Given this list of marker genes H1-3, HMGB2, H1-0, H1-2, KPNA1, H1-5, DFFA, CASP3, KPNB1, H1-1, H1-4, HMGB1, DFFB, here is a description of the gene set: Human Gene Set: REACTOME_APOPTOSIS_INDUCED_DNA_FRAGMENTATION Apoptosis induced DNA fragmentation species: Homo sapiens